Given this list of marker genes ZFP36L2, RAB11FIP1, PPP4R3B, KLF5, PHF14, RNF19B, GADD45A, PHLDA3, ID2, H3-3B, TNFSF9, TIGAR, PLK2, IER3, BBC3, JUN (Jun proto-oncogene, AP-1 transcription factor subunit), SOX9 (SRY-box transcription factor 9), NUDT15, ATF3, RGS16, HCAR3, MNT, PTGER4, HAPSTR1, CDC25A, CD83, MDM2, IER5, CLK1, SLC7A11, AEN, SGK1, FOSL1, ELK4, RRAD, ZBTB10, SESN1, FAS, NUP160, TNFRSF10B, PPP1R15A, CDKN1A, CCL3, PIM1, HLA-DPA1, PCIF1, PPM1D, INKA2, SENP6, SLC30A1, GDF15, PMAIP1, PSMD11, here is a description of the gene set: Genes up-regulated in B lymphocytes at 2 h after exprosure to 10 Gy dose of ionizing radiation. Human Gene Set: SMIRNOV_RESPONSE_TO_IR_2HR_UP studied in species Homo sapiens from publication Smirnov DA, Brady L, Halasa K, Morley M, Solomon S, Cheung VG (PMID 21844125) Radiation exposure through environmental, medical, and occupational settings is increasingly common. While radiation has harmful effects, it has utility in many applications such as radiotherapy for cancer. To increase the efficacy of radiation treatment and minimize its risks, a better understanding of the individual differences in radiosensitivity and the molecular basis of radiation response is needed. Here, we integrated human genetic and functional genomic approaches to study the response of human cells to radiation. We measured radiation-induced changes in gene expression and cell death in B cells from normal individuals. We found extensive individual variation in gene expression and cellular responses. To understand the genetic basis of this variation, we mapped the DNA sequence variants that influence expression response to radiation. We also identified radiation-responsive genes that regulate cell death; silencing of these genes by small interfering RNA led to an increase in radiation-induced cell death in human B cells, colorectal and prostate cancer cells. Together these results uncovered DNA variants that contribute to radiosensitivity and identified genes that can be targeted to increase the sensitivity of tumors to radiation.